The following is a description of a gene set: studied in species Mus musculus Mouse Gene Set: GOBP_VALINE_CATABOLIC_PROCESS The chemical reactions and pathways resulting in the breakdown of valine, 2-amino-3-methylbutanoic acid., and this is the list of marker genes: Bckdk, Aldh6a1, Acad8, Hibadh, Hibch